The following is a description of a gene set: species: Mus musculus Mouse Gene Set: chrXF1, and this is the list of marker genes: Gm8036, Gm4917, Gm15001, Frmpd3, Dnaaf6, Gm15045, Nxf7, Gm15011, Gm14991 (NCBI Gene Id 102633681), Arxes1 (NCBI Gene Id 76219), Gm6215, Mir3475, Gm6298, Rnf128, Rab9b, Gm6088, Gm23958, Gm6275, Il1rapl2 (interleukin 1 receptor accessory protein-like 2), Gm7905, Gprasp2, Arxes2, Gm15022, Tceal1, Rbm41, Gm15044, Mir1970, Gm15004, Pramex1, Bex2, Zcchc18, Esx1, Vsig1, Tmsb15a, Bex3, H2bw2, Gm15040, Gm8061, Tsc22d3, Pramel3e, Armcx5, Plp1, Prps1, Tceal3, Gm15047, Gm15010, Ripply1, Psmd10, Pramel3d, Gm7091, Gm15007, Gm15006, Tmsb15l, Morf4l2, Gm6207, Mir7646, Gm25770, Pramel3b, Gm6228, Nrk, Tbc1d8b, Pramel3a, Gm6322, Gm5761, Pwwp3b, Cldn2, Tex13b, Eif2c5l, BC065397, Nsa2-ps2, Bex1, 3632454L22Rik, Gm14994, Gm15046, Nxf3, Gm15013, Gm6221, Gm14999, Kir3dl1, Gm8097, Tceal5, 4930513O06Rik, Bex4, Morc4, Trap1a, Tceal9, Gprasp1, Gm8019, Gm15016, Gm15021, Gm23199, Gm15039, Atg4a, Gm15041, Tceal8, Pramex2, Gm15026, Mid2, Tceal7, Gm15000, Btf3-ps3, Tex13a, Gm15043, Gm15038, Tmsb15b2, Tmsb15b1, Glra4, Nup62cl, Fam199x, Gm15078, Gm15042, Serpina7, Radx, Tceal6, Tcp11x2, Slc25a53, Platr21, Gm15002, 5730412P04Rik, Mir6383, Kir3dl2, 4933428M09Rik, Gm14989, Pramel3c, Bhlhb9 (NCBI Gene Id 70237), Gm14997